Given this list of marker genes WT1, GNAQ, TAP1, TGFBR1, SMAD3, PAK2, CYSLTR2, ADAMTS17, TGFB2, NDP, BAP1, COL5A1, LOXL1, MOCS2, PORCN, SUOX, FOXC1, ADAMTS10, ELP4, ASPH, P3H2, B3GALT6, PAX2, FBN2, COL2A1, SF3B1, PAX6, LTBP2, MOCS1, HSPG2, AASS, PCYT1A, FBN1, GNA11, BMP4, SALL2, C12orf57, BCOR, CPAMD8, CHRDL1 (NCBI Gene Id 91851), TRIM44, COL11A1, CBS, COL18A1, TGFBR2, ADAMTSL4, here is a description of the gene set: Human Gene Set: HP_ECTOPIA_LENTIS Dislocation or malposition of the crystalline lens of the eye. A partial displacement (or dislocation) of the lens is described as a subluxation of the lens, while a complete displacement is termed luxation of the lens. A complete displacement occurs if the lens is completely outside the patellar fossa of the lens, either in the anterior chamber, in the vitreous, or directly on the retina. If the lens is partially displaced but still contained within the lens space, then it is termed subluxation. studied in species Homo sapiens Ectopia lentis